The following is a description of a gene set: Human Gene Set: TAGAACC_MIR182 studied in species Homo sapiens Genes having at least one occurence of the motif TAGAACC in their 3' untranslated region. The motif represents putative target (that is, seed match) of human mature miRNA hsa-miR-182* (v7.1 miRBase)., and this is the list of marker genes: ZFP36L2, RBM12, BCL2L2, CNTN2 (NCBI Gene Id 6900), RAB5A, FAT1, AMZ2P1, GALNT1, HOXB4, HYCC2, FAM107B, CNOT6, SLC6A4, CADM1, ISCA1, BAAT, NUP153, UBE2B, SRSF1, ACYP1, CXXC5, CRIM1, ZNF800, SLC16A7, DOCK9, SRSF10, RNF6, ZNF532, HDHD2, FLI1, PRMT8, TBR1, FAM78B, CREM, LSM14B, SEC22B, DDX3X, NHS, FXR2